The following is a description of a gene set: A developmental process, independent of morphogenetic (shape) change, that is required for the hindbrain to attain its fully functional state. The hindbrain is the region consisting of the medulla, pons and cerebellum. Areas of the hindbrain control motor and autonomic functions. Human Gene Set: GOBP_HINDBRAIN_MATURATION studied in species Homo sapiens, and this is the list of marker genes: CEND1, CDK5R1, ARCN1, CDK5R2, RERE